Given this list of marker genes Tenm2, Olfm2, Scrib, Rnf10, Ppp1r9b, Magi2, Nptx2, Akap9, Cyth2, Nbea, C1qa, Ctnna2, Tiam1, Olfm1, Fbxo2, C1qb, Fgf22, Dgki, Crkl, C1qc, Farp1, Cnksr2, Dgkb, Vwc2, here is a description of the gene set: Mouse Gene Set: GOCC_EXTRINSIC_COMPONENT_OF_POSTSYNAPTIC_MEMBRANE species: Mus musculus The component of the postsynaptic membrane consisting of gene products and protein complexes that are loosely bound to one of its surfaces, but not integrated into the hydrophobic region.